The following is a description of a gene set: Genes containing one or more binding sites for (ZNF260) in their promoter regions (TSS -1000,+100 bp) as identified by GTRD version 20.06 ChIP-seq harmonization. Human Gene Set: ZNF260_TARGET_GENES from publication Yevshin I, Sharipov R, Kolmykov S, Kondrakhin Y, Kolpakov F (PMID 30445619) studied in species Homo sapiens, and this is the list of marker genes: JOSD2, NIF3L1, ZC3H10, CC2D2A (coiled-coil and C2 domain containing 2A), DNAJC9, MRPL48, DUS1L, ZNF382, TRIM46, ZNF335, FBXO22, SHC4, AP3S2, C10orf88, PARPBP (PARP1 binding protein), METTL1, HMGA2, RGS5, MKRN2, DIS3L, ENSG00000267058, NDUFAF3, TLE2, AKAP6, ZNF343, TFAP4, VWA8-AS1, TMEM222, ALG10B, ARID4B, RNF213-AS1, RPLP1, RTEL1-TNFRSF6B, FUT4, RAB3GAP1, EXD2, EMC3, CDC42EP4, MCF2L, PLK5, GFRA1, ZNF420, DALRD3, OGT, ARMCX5, TFPT, RBM28, H4C2, TMEM144, PFKL, CDIPTOSP, KPNB1, SIKE1, PSMD1, POLR3B, AURKAIP1, ENSG00000252404, HSD17B1-AS1, NDUFA11, ALKBH3, SLC35A3, HEBP2, NDUFB7, TSFM, ERCC6L2, FAF1, ODAD4, ADAT2 (adenosine deaminase tRNA specific 2), ZZZ3, PDXK, DDIT4, BCL9, C3orf38, CARD8-AS1, PDE4B, DET1, MTMR9, ZNF165, DMAP1, LINC01010, NAPG, IMPDH2, CCDC18 (NCBI Gene Id 343099), LINC01811, MAP2K3, PRKCE (protein kinase C epsilon), GPR39, COG2, ZNF793, PTPN2, MICB, DYRK4, VTRNA1-2, METTL15, EXOSC6, VMAC, PRSS27, ITFG2-AS1, ANXA2, CCDC180, ZNF234, ANAPC5, FAM76B, ADNP, GGPS1, RPL7L1, DHRS4-AS1, KCTD10 (NCBI Gene Id 83892), SYCP2L, RPS29P16, TMEM101 (transmembrane protein 101), SULF2, CCNI, PMAIP1, ENDOV, TVP23B, AGGF1, IZUMO4, AGAP2, THAP10, POLD1, GINS1, ISLR2, TMEM259, CCDC159, NME1-NME2, DIS3L-AS1, CLPTM1, WDR11, MAN2C1, EXOSC8, MTND5P11, PCLAF, TTI2, CCDC97, SF3A3, METTL18, CNTNAP2, UBA2, CZIB-DT, TCN1, ANKRA2, BMS1P4 (BMS1 pseudogene 4), ZNF106 (NCBI Gene Id 64397), INTS12, RNU7-27P, BRF2, RPL3P2, EAF1 (ELL associated factor 1), AQR, LRRC49, PPP1R3D, UQCR11, CHAC1, AAR2, RAB11A, ZSCAN26, FBXW9, SUPT5H, NUDT19-DT, PHAF1, TOR1AIP1, CNIH3, NCAM1, PEX13, KBTBD4, MRPS18C, SNAPC5, RPL27, ANKRD24, VAV1, MIR3613, AARS2, RPL26L1 (ribosomal protein L26 like 1), TUBGCP4, CPE, EDC4, ANKEF1, CLASP1, NPM1, MTOR, TNPO2, VARS2, KLHDC1, SCP2, RPS24, ARID1A, ZDHHC6, GPRIN3, ACLY, GPR85, SNAP23, SRSF7, CZIB, SNUPN (NCBI Gene Id 10073), ECI1, GRAMD1A, LIG4, ZNF821, COMMD2, ATPAF2, GLUD1P3 (NCBI Gene Id 414244), KPNB1-DT, PSTK, NDUFC2, EPB41L3, GRAMD1A-AS1, RBL1, KANSL3, LMAN2, RNA5SP18, CBFB, JMJD1C, DOCK7, STMN3, JRK, ENSG00000267260, PARP6, H2BC5, ZNF282, COPS7B, GEMIN6, ZNF569, TDP2, UBL7-DT, SETD1A, PPP6R3, COQ8B, HADHA, NDUFAF4P1, MRPS31P5, PSCA (NCBI Gene Id 90297), ITPK1P1, GEMIN4, SNHG19, NDUFAF1, MCM3AP, DDN, THUMPD1, RBSN, CFAP298, SEL1L3, INKA2, DCDC1, PIGBOS1, KLHL26, ZMYND8, TMEM242 (transmembrane protein 242), RNU5A-1, NUP43, REXO4, DTNA, TMEM79, C17orf75, AIFM1, SAR1B, PTP4A1, LZIC, STX16, RNU5F-1 (RNA, U5F small nuclear 1), RPS23P10, NKAP, KCNK1, PUS10, NOL12, SNRPE, ABCD1, FDX2, ST7L, ZNF181, ACOT13, SLX9, MXI1, XIST, EML2, DNAJC25, DNAJC24, FAM136A, MNAT1, ESYT1, CDK12, LAMP1, NUB1, GRB2 (NCBI Gene Id 80715), MIR3190, OTULIN-DT, TAOK3, UTP15, STAT3, GLUD1P2, OTUD7B, GMDS, AGAP1, DNM1, ARL5A, CDIPT, ATP2B4, NDUFC2-KCTD14, SLC30A6-DT, CENPU, DNAJC19, PIERCE1, ZCCHC8, NR2F1, MRPS31P4, PROSER3, RBM42, BRWD1, COG3, RPL37, NOSIP, CERNA3, RN7SL392P, WDPCP, PSMG4, CROCCP2, TBC1D19, HELQ, KCTD9, ZNF827, PRRG2, FAM227B, PEX12, HLA-DMA, RBBP5, CARS2, MEGF10, PLEKHM3, CIZ1, DNAJC25-GNG10, FASTKD5, ALKBH2, PLCB2-AS1, FAM230G, PHIP, ENSG00000267024, KRT18P12, MARCKSL1P2, LINC01775, RNU11, ZNF764, TEX11, TEFM, RPL26L1-AS1 (RPL26L1 antisense RNA 1), ZMPSTE24, TRDMT1, TSPAN31, INO80B, ZNF213-AS1, CCNC, ZSCAN16-AS1, ITGA9-AS1, CSTF2T, MST1P2, MED23, IGHMBP2 (immunoglobulin mu DNA binding protein 2), FRA10AC1, SNORA16A, STX16-NPEPL1, METTL6, ZNF568, PDCD6IP, LSM5, PSMG3-AS1, PYURF, MRPL53, EMC3-AS1, MIR1277, CDCA2, ATP5F1A, SLC39A3, PSMC1, CGGBP1, MED18, SMG7, SMG8, ATG4C, GPBP1L1, PRDX1, GALNT16-AS1, CFAP298-TCP10L, HEXIM2, ADAMTS3, CFAP410, BICDL3P, DNAH2, COX16, MIR7-3HG, EIF5A, HEXIM2-AS1, RNVU1-21, PHB2, CAPZA1, TACO1, BMPR1B, AJUBA, SLC30A6, CMC2, CHEK2, MIGA1, ESF1, DBIL5P, ZC3H6 (NCBI Gene Id 376940), HDAC2, INTS14, ZNF283, KCND1, FIRRM, TAMM41, MTCO3P12, RAB27A, UBE3B, PRPF31, ADAP2, RNF150, KCNH2, RPS4X, GNAL, TRAPPC8, PPIL3, RELN, MORN4, CFAP65, PCDH1, RPS20, MAP2K5, EEF1A1, ZBTB14, MIR7-3, PGS1, FBXW8, GOSR1, RNF207, CEBPG (NCBI Gene Id 1054), MOB3A, ABRACL, ARID5B, EIF3F, CCDC77, NOP16, NBL1, MTIF2, CDK5RAP1 (CDK5 regulatory subunit associated protein 1), TXLNB, ANKRD40, SLC44A1, SOX13, ZNF391, NDUFA2, C2CD5, ENSG00000232995, RNU6-131P, SLC33A1, DYTN, ADGRE2, RPS7, EEF1A1P8, HIC1, PRPF18, REX1BD, MRPS34, SEPTIN7P13, WARS1, UBOX5, ADAM22, RRP15, PCID2, ZNF45-AS1, EPC1-AS2, JPX, BCAS2, ZNF549, ZKSCAN2, VEGFA (vascular endothelial growth factor A), SNORD46, ZNF780A, DPY19L4, POLI, CWF19L1, CHMP4A, ATAD3A, RPL12P21, UTP3, ENSG00000259362, HERC3, RGS3, CALCOCO1, BNIP1, RPS17, SLC24A1, ENSG00000231252, EIF3E, RPL29, LINC02773, POLB, CCDC22 (coiled-coil domain containing 22), PPP6R1, LRP12, SLC27A5, RNU6-2, CITED2, ZSCAN30, ZNF260, RAI14, IFTAP, ZNF461, GTPBP3, CBX5, LINC02942, HSPB6, CCAR1, SUGCT, LMO4, BRD2, SMG7-AS1, MRPL54, NDUFS3, ENPP3, PSMG3, ELOVL2-AS1, COX7A2 (NCBI Gene Id 1347), NME1, IPO4, PIWIL4, CES3, SLC4A1AP, PROX1-AS1, ATP8B1-AS1, MIR5087, SPOP, MIR4512, ATP6V0A2 (NCBI Gene Id 7854), MRPL30, ZNF302, ASB6, SLC25A36, COQ3, MEF2A, GPR42, LTN1, CCNE1, CHCHD2, PREX2, RPS15, IST1, SPRED1, WDR36, ST7, MRPS22, RPS4XP19, NDUFA12, MIA2, SHF (NCBI Gene Id 90525), POP4, LRRC37A5P, ZDHHC9, PTCH1, ZNF195, OTULIN, UBL7, PEX3, ZNF224, TBC1D5, NKAPP1, LINC02643, ZNF579, WSCD1, NUDCD1, BCO2, WDR24, EME2, PIGQ, LGI4, KIAA1671, ARAP1, ZNF271P, TMBIM6, GIN1, POLDIP3, LINC01719, DOCK7-DT, ETS2-AS1, USPL1, SEC16B, LAS1L, ATN1, GALK2, RAB3IP, GBA1, PGBD4, FAM228B (family with sequence similarity 228 member B), SMC6, H2BC18, VTI1A, KCTD5 (potassium channel tetramerization domain containing 5), MRPL44, PAFAH2, P2RX3, ENSG00000247416, SRFBP1, CFAP74 (cilia and flagella associated protein 74), SNORD55, ADGRE5, ZNF689, TOB2, GFM2, C18orf32 (chromosome 18 open reading frame 32), MRPS33, SUPT7L, SNORD54, NECAP1, DNAJC9-AS1, DIP2C, ALG5, PCYT1A, LINC01804, GPATCH3, CWC27, TBCD, VPS25, MTF2, KRT86, COL13A1, EFCAB10, RTEL1, NAA25, KLHDC9, WDR25, YIPF2, KRT8, HUS1, TIMM29, ZNF205, GUSBP2, ADIPOR2, AJUBA-DT, MRPS27 (mitochondrial ribosomal protein S27), TMEM69, SNAP47, MTERF4, NOC3L, TAS1R1, RCOR1, DDX41, PNPLA6, RFX2, LATS2, VPS51, TATDN3, LINC00240, NSL1, TMEM128, SMG5, MRPS31, MRPS2, EMC7, EHMT1, SPSB1, LSG1, SSBP1, ERCC6L2-AS1, NBPF1, DSTYK, DCTN6-DT, LINC01275, WASF4P, SNRPD1, EIF1AD, GTF3C3, NUDT7, GSTCD (NCBI Gene Id 79807), ZNF829, LINC02960, COQ8A, RNA5SP21, ABHD13, VPS13B-DT, APBA3, SF3B6, ING1 (inhibitor of growth family member 1), RELA, NFE2L2, RNU1-134P, KDM5A, DIMT1 (DIM1 rRNA methyltransferase and ribosome maturation factor), MRPL21, PPIP5K2, RAB18, WDR70, RNVU1-27, GTF3C5, NR1H2, RPL38, TMEM242-DT, RTTN, GTF2IP20, TSHZ2, ZMPSTE24-DT, TRAF7, PIGB, C12orf76, NDUFS7, BPNT1, ENTPD1-AS1, ENSG00000263011, OSBPL7, NUF2, BANF1, BMS1P4-AGAP5, TFCP2, ZNF546, WEE2-AS1, H2BC12, POLR2J3, SLC22A15, GABPB2, TRIP4, PDE6D, MDH1 (malate dehydrogenase 1), MEIS1, RARS1, PSMC2, DUSP6, SAMD4B, SNHG3, FOXJ3, TRPV1, ZNF354B, EGLN2, VTRNA1-3, AP1G1 (adaptor related protein complex 1 subunit gamma 1), MRPL39, ZNF613, ZNF875, ZNF233, RPL12P24, TP53BP2, ADCY10, TUBB2B (NCBI Gene Id 347733), PPP4R3A, BCL11B, RRN3P1, TMEM41A, MIF4GD-DT, ZNF622, SMARCD2, ZNF580, RPS8, BRAF, YBEY, UBE2V1P4, RNU4ATAC, CUL4A, ZNF554, HDAC2-AS2, CDC42SE1, CLASP2, C5orf52, NDUFAF5, SNRNP27, RERE, RCC1, JCHAIN, PCBP2 (poly(rC) binding protein 2), PDCD6P1, EXOSC3, MPLKIP, TOP3B, ZC3HC1, SIRT6, LINC02953, EMC4, ZBTB45, PSMC4, TARS2, PSMB6, STAT1, CKB, MRPL3, COPS2, CMTM7, LGI1 (leucine rich glioma inactivated 1), PABPN1, BMS1, NUP37, SDC2 (syndecan 2), RN7SL819P, SEMA6D, MLEC, SNHG12, SNRNP35, NOL9, AXDND1, IFT56, RNF41, CCDC81, IGFLR1, INO80B-WBP1, KRTCAP2, ZCCHC4, ZNF540, SNHG7, N4BP3, LYPD5, ZNF793-AS1 (ZNF793 antisense RNA 1 (head to head)), DTWD1 (DTW domain containing 1), PPP4R1, IPO11, RUVBL1, TTC5, HSPB1P2, ANXA2R, SNRPB, LIN37, H2AC12, PIGL, MTR, DRG2, MIR4521, SLC38A7, EEF1AKMT3, DNM1P38, UBP1, VWA8, SOX2-OT, ALG10, ZBTB40, FBXW7, NUDT19, CCNG2, RBM45, GTF2H4, IK, SPOCD1, FRMD4B (FERM domain containing 4B), LINC01409 (NCBI Gene Id 105378581), VPS13B, GTF2H2C (GTF2H2 family member C), HMGB1 (high mobility group box 1), SEMA3A, CCAR2, INTS2, SREK1IP1, APBA1, RABEP2, NREP, LINC01547, GID4 (NCBI Gene Id 79018), JMJD4, MBTPS2, ZNF221, ZNF846, EID1, PHF3, RNU1-94P, MIR3143, ZNF570, ZKSCAN8, MIF4GD, STOX1, UQCC1, NMNAT1, EMG1, RPS23P9, SEC22B, MITD1, CCNJL, GOLIM4, KIFBP, SNORD60, ZNF404, ZNF608, ANO8, STAT6, TSC2 (TSC complex subunit 2), CRYM, ZNF581 (NCBI Gene Id 96067), RN7SKP59, WDR11-DT